Given this list of marker genes Pdgfb, Nfkb1, Has2, Egf (NCBI Gene Id 99717), Ptger4, here is a description of the gene set: Any process that activates or increases the frequency, rate or extent of hyaluronan biosynthetic process. Mouse Gene Set: GOBP_POSITIVE_REGULATION_OF_HYALURONAN_BIOSYNTHETIC_PROCESS species: Mus musculus